The following is a description of a gene set: species: Homo sapiens An abnormal concentration of potassium(1+) in the urine. Abnormal urine potassium concentration Human Gene Set: HP_ABNORMAL_URINE_POTASSIUM_CONCENTRATION, and this is the list of marker genes: CTNS, NDUFAF6, SLC12A3, CYP11A1, CLCNKA (NCBI Gene Id 1187), GABRA3, ATP1A1, GATM, KCNJ18, EHHADH, CACNA1S, KCNJ10, SLC34A1 (NCBI Gene Id 8561), SERPINA6 (NCBI Gene Id 866), KCNJ1, CLCNKB, BSND, SLC12A1